The following is a description of a gene set: studied in species Mus musculus Mouse Gene Set: GOBP_PROTEIN_INSERTION_INTO_MITOCHONDRIAL_INNER_MEMBRANE The processes mediating the insertion of proteins into the mitochondrial inner membrane. Mitochondrial inner membrane proteins can get inserted from the cytosol, by crossing the outer membrane and being guided by an inner membrane translocase complex into their final destination in the inner membrane. Some proteins present in the intermembrane space can get inserted into the inner mitochondrial membrane. Finally, some proteins are inserted into the inner membrane from the matrix side of the membrane., and this is the list of marker genes: Timm9, Agk, Romo1, Ndufa13, Timm29, Timm22, Tomm70a, Trmt10b, Timm13, Timm10